The following is a description of a gene set: studied in species Mus musculus Mouse Gene Set: GOBP_SYMPATHETIC_NERVOUS_SYSTEM_DEVELOPMENT The process whose specific outcome is the progression of the sympathetic nervous system over time, from its formation to the mature structure. The sympathetic nervous system is one of the two divisions of the vertebrate autonomic nervous system (the other being the parasympathetic nervous system). The sympathetic preganglionic neurons have their cell bodies in the thoracic and lumbar regions of the spinal cord and connect to the paravertebral chain of sympathetic ganglia. Innervate heart and blood vessels, sweat glands, viscera and the adrenal medulla. Most sympathetic neurons, but not all, use noradrenaline as a post-ganglionic neurotransmitter., and this is the list of marker genes: Insm1, Gdnf, Fzd3, Nrp1 (neuropilin 1), Sema3a, Plxna4, Gfra3, Sema3f, Erbb2, Nf1, Nrp2, Tfap2b, Sox4, Ctnnb1, Tfap2a, Phox2b, Hand2, Ntrk1 (neurotrophic tyrosine kinase, receptor, type 1), Trp63, Gata3, Ednra, Phox2a, Sox11, Ascl1